Given this list of marker genes Osbpl2, Pitpnb, Gltp, Prelid3b, Pitpna, Esyt1, Pltp, Gltpd2, Scp2, Mttp, Prelid1, Pitpnc1 (phosphatidylinositol transfer protein, cytoplasmic 1), Prelid3a, Triap1, Bltp1, Abca3, Prelid2, C2cd2l, Plekha8, Tnfaip8l3, Cptp, Pitpnm1, Pitpnm2, here is a description of the gene set: Removes a phospholipid from a membrane or a monolayer lipid particle, transports it through the aqueous phase while protected in a hydrophobic pocket, and brings it to an acceptor membrane or lipid particle. Mouse Gene Set: GOMF_PHOSPHOLIPID_TRANSFER_ACTIVITY species: Mus musculus